Given this list of marker genes LARP7, SDHAF1, SDHA, THOC6, ASPA, GRIN2B, UBE3A, OCA2 (OCA2 melanosomal transmembrane protein), SDHB, RIC1, COG6, PLAG1, CEP85L, GATA6, SDHD, TRAPPC9, CWF19L1, here is a description of the gene set: Mild microcephaly studied in species Homo sapiens Decreased occipito-frontal (head) circumference (OFC). For the microcephaly OFC must be between -3 SD and -2 SD compared to appropriate, age matched, normal standards (i.e. -3 SD <= OFC < -2 SD). Human Gene Set: HP_MILD_MICROCEPHALY